The following is a description of a gene set: from publication Shipp MA, Ross KN, Tamayo P, Weng AP, Kutok JL, Aguiar RC, Gaasenbeek M, Angelo M, Reich M, Pinkus GS, Ray TS, Koval MA, Last KW, Norton A, Lister TA, Mesirov J, Neuberg DS, Lander ES, Aster JC, Golub TR (PMID 11786909) studied in species Homo sapiens Diffuse large B-cell lymphoma (DLBCL), the most common lymphoid malignancy in adults, is curable in less than 50% of patients. Prognostic models based on pre-treatment characteristics, such as the International Prognostic Index (IPI), are currently used to predict outcome in DLBCL. However, clinical outcome models identify neither the molecular basis of clinical heterogeneity, nor specific therapeutic targets. We analyzed the expression of genes in diagnostic tumor specimens from DLBCL patients who received cyclophosphamide, adriamycin, vincristine and prednisone (CHOP)-based chemotherapy, and applied a supervised learning prediction method to identify cured versus fatal or refractory disease. The algorithm classified two categories of patients with very different five-year overall survival rates (70% versus 12%). The model also effectively delineated patients within specific IPI risk categories who were likely to be cured or to die of their disease. Genes implicated in DLBCL outcome included some that regulate responses to B-cell-receptor signaling, critical serine/threonine phosphorylation pathways and apoptosis. Our data indicate that supervised learning classification techniques can predict outcome in DLBCL and identify rational targets for intervention. Human Gene Set: SHIPP_DLBCL_CURED_VS_FATAL_UP Top 50 up-regulated markers for the diffused large B-cell lymphoma (DLBCL) that distinguished between cured and fatal/refractory clinical outcomes., and this is the list of marker genes: DNAH12, ITGAD, SERPINB8, IGF2, NR4A3, RORA, NTF3, SLC11A1, GATA1, FXYD2, ATP2A1, LTA, MAP1B, AKR1C1, MMP1, PRKCG, SLC38A3, ARC, AKT3, CYP4A11, MLC1, HTR2B, RAB40AL, SOX4, CLCNKB (NCBI Gene Id 1188), NPTX2, CTSE, GNA15, MYL4, FAAH, GPR12, ZNF91, DRP2, FUT1, SELE, CES1, CHRNA3, APLP1, EYA3